Given this list of marker genes Fundc2, Tomm7, Ulk2, Gabarapl1, Atg10, Snx30, Atg12, Atg4c, Bcl2l13, Hk2, Vps13d, Lrba, Mul1, Srebf1, Dele1, Cdkn2a, Abi2, Atg5, Dnm1l, Slc25a5, Atg2a, Gsk3a, Cdc37, Tspo (NCBI Gene Id 12257), Ulk3, Eif2ak1, Timm23, Atg7, Stub1, Tafazzin, Map1lc3a, Atg4a, Phb2, Snx7, Irgm2, Slc25a4, Trp53 (NCBI Gene Id 22059), Bnip3l, Ambra1, Wdr45b, Htra2, Optn, Atg2b, Sqstm1, Pink1, Vps13c, Atg4d, Huwe1, Nipsnap3b, Usp30, Rb1cc1, Wipi2, Atg4a-ps, Pptc7, Parl, Fis1, Arhgap26, Wdr45, Ogt, Eif2s1, Fbxw7, Fundc2b, Becn1, Fbxo7, Fbxl4, Fkbp8, Nod2, Atg9b, Vdac1, Gabarap, Adcy10, Nipsnap1, Cttn, Atp5if1, Nipsnap2, Bnip3, Retreg1, Spata18, Fundc1, Atg3, Atg4b, Cisd2, Mfn2, Ulk1, Arfip2, Atg9a, Igtp, Atg14, Clec16a, Map1lc3b, Gabarapl2, Wipi1, Tigar, Prkn, Hdac6, Cers1, Htt, Spata33, Gba1, Becn2, Smurf1, Rnf41, Slc25a46, Rimoc1, Atg13, Irgm1, Ube2a, here is a description of the gene set: The autophagic process in which mitochondria are delivered to a type of vacuole and degraded in response to changing cellular conditions. studied in species Mus musculus Mouse Gene Set: GOBP_AUTOPHAGY_OF_MITOCHONDRION